The following is a description of a gene set: studied in species Homo sapiens Human Gene Set: MIR3165 from publication Chen Y, Wang X (PMID 31504780) Genes predicted to be targets of miRBase v22 microRNA hsa-miR-3165 in miRDB v6.0 with MirTarget v4 prediction scores > 80 (high confidence targets)., and this is the list of marker genes: GARIN1A, NBEA, SH2B3, SCN1B, C18orf54, NCMAP, PPARA, PKNOX2, ITGA9, RAP1B, HDAC2, NCAPG2, ACIN1, NEK4, ARMCX2, DDX50, GOLGA7B, PHB1, SYNJ2, SRPK1, ERC1 (NCBI Gene Id 84770), PRIMA1, YWHAG, JAKMIP3, SMG1, PURA, ENTPD6, AVIL, MPV17L, DERL2, SHISA7, CXXC4, CAPZA1, RFX5, SMG6, CRYBG3